The following is a description of a gene set: The directed movement of bile acid and bile salts into, out of or within a cell, or between cells, by means of some agent such as a transporter or pore. studied in species Mus musculus Mouse Gene Set: GOBP_BILE_ACID_AND_BILE_SALT_TRANSPORT, and this is the list of marker genes: Slc10a7, Slc10a1, Aqp8, Slc10a4, Cyp7a1 (cytochrome P450, family 7, subfamily a, polypeptide 1), Abcc3, Mip (NCBI Gene Id 17339), Abcb11, Abcd3, Atp8b1, Abcc4, Slc10a4-ps, Slc51a, Slco1a6, Hnf1a, Slc51b, Slco1a8, Slco1c1, Fgf15, Slco1a4, Nr0b2, Slco1b2, Abcc2, Slco2b1, Slco1a1, Slc10a6, Slc10a2, Slco1a7, Ceacam2, Ceacam1, Aqp9, Slc10a5, Slco1a5, Nr1h4, Slc10a3